The following is a description of a gene set: species: Mus musculus The aggregation, arrangement and bonding together of a set of components to form the AIM2 inflammasome complex. Mouse Gene Set: GOBP_AIM2_INFLAMMASOME_COMPLEX_ASSEMBLY, and this is the list of marker genes: Ifi203-ps, Ifi213 (interferon activated gene 213), Gm12250, Trim11, Casp1, Gbp5, Gbp2, Ifi214, Aim2, Ifi206, Ifi208 (NCBI Gene Id 100033459), Ifi207, Ifi203, Mndal, Ifi209